Given this list of marker genes H2bc11 (NCBI Gene Id 319183), H2ac6, H2ac15, H4c1, H2bc9, H2ac10, H4c11, H2ab3, Acd, H3f4, H2bc13, H2ac13, Atrx, H2ac18, H4c17, H4c12, H4c14, H4c6 (NCBI Gene Id 319157), H2bc22, H2ac8, Pot1a, Daxx (Fas death domain-associated protein), H2bc23, H2ac11, H2ac20, H2aj, H2ac7, H2bc21, H2bc15, H3f3b, H4c16, H2ac12 (H2A clustered histone 12), H2bc1, H2ac22, Terf2ip, H4c4, H4c3, H4c2, H2ac19, H2az2, Terf1, H2ac4, Terf2, H3f3a, H2bc8, H4c18, H2ax, H4c8, H2bc3, H2ac23, H2bc4, H2bc14, H2ac24, H2ab1, H4c9, H2bc12, H2bc7, H2bc6, H2bc26, H2bc24, H2ab2, here is a description of the gene set: Mouse Gene Set: REACTOME_INHIBITION_OF_DNA_RECOMBINATION_AT_TELOMERE species: Mus musculus Inhibition of DNA recombination at telomere